Given this list of marker genes Il1rap, Nptn, Nlgn1, Dag1, Il1rapl1 (interleukin 1 receptor accessory protein-like 1), Farp1, Cadm1 (cell adhesion molecule 1), Ptprd, Efnb3, Tenm2, here is a description of the gene set: Cell-cell signaling between presynapse and postsynapse mediated by a trans-synaptic protein complex. Mouse Gene Set: GOBP_TRANS_SYNAPTIC_SIGNALING_BY_TRANS_SYNAPTIC_COMPLEX studied in species Mus musculus